The following is a description of a gene set: The movement of an organism or part of an organism using mechanoreceptors, the nervous system, striated muscle and/or the skeletal system that can be controlled at will. Mouse Gene Set: GOBP_VOLUNTARY_MUSCULOSKELETAL_MOVEMENT species: Mus musculus, and this is the list of marker genes: Xrcc1, Hipk2, Spr, Itpr1, Mtor, Map1a, Vti1a, Vps35